The following is a description of a gene set: part of: Metabolism of RNA studied in species Mus musculus electronically inferred by orthology from the curated human pathway This event has been computationally inferred from an event that has been demonstrated in another species.<p>The inference is based on the homology mapping from PANTHER. Briefly, reactions for which all involved PhysicalEntities (in input, output and catalyst) have a mapped orthologue/paralogue (for complexes at least 75% of components must have a mapping) are inferred to the other species. Reactome Pathway: rRNA processing, and this is the list of marker genes: Rpl39l, Rps27l (ribosomal protein S27-like), Rpl11, Ddx52, Rpl7, Utp6, Rpl26, Eri1, Pelp1, Mtrex, Rpl4, Nol11, Dcaf13, Fcf1, Xrn2, Riok3, Rrp36, Rplp2, Rpl19, Rpl9, Rps23, Utp11, Gnl3, Rpl36al, Rpl37rt, Rps5, Ddx21, Rps20 (NCBI Gene Id 67427), Senp3, Rpp14 (NCBI Gene Id 67053), Nob1, Rps28, Ubb, Rrp9, Rpp21, Snu13, Emg1 (EMG1 N1-specific pseudouridine methyltransferase), Pes1, Rps26, Rps3a1, Rpl36a, Rpl38, Rpl3, Rpl14, Rpl12, Rps10, Fau, Rpl6, Rps25, Pno1, Nop56, Rpl24, Rps17, Wdr43, Rps18, Rpl13, Ltv1 (LTV1 ribosome biogenesis factor), Rps13, Rps15, Las1l, Utp4, Rps8, Rrp7a, Bud23, Exosc10, Rps6, Rpl37, Rpl27a, Rpl18a, Rps9, Rpl18, Rpl27, Rps24, Rpl39, Rpp25, Rps11, Rps12, Nop14, Rpl37a, Fbl, Rpl3l, Rps19 (ribosomal protein S19), Nop58, Rpl29, Rps4x, Rps7, Rps2, Rpl15, Rpl23a, Csnk1e